Given this list of marker genes CLU, KDM5C, ZNF709, AFTPH, DDX3X, CHCHD2 (coiled-coil-helix-coiled-coil-helix domain containing 2), HSPH1, AZIN1, HOXB8, ZNF225, COLQ, PRDM10, ARL10, TTC39A, NSD2, AP3S1, PHF20L1, KRT78, PTGER4, FRY, DACT1, MDM4, CTAGE1, FBN1, GBE1, DDB2, PDE3B, XKR4, VTI1B, PPP6R3, BMP2, FMR1, LRRC10, JDP2, here is a description of the gene set: Genes predicted to be targets of miRBase v22 microRNA hsa-miR-6813-3p in miRDB v6.0 with MirTarget v4 prediction scores > 80 (high confidence targets). Human Gene Set: MIR6813_3P from publication Chen Y, Wang X (PMID 31504780) studied in species Homo sapiens